Given this list of marker genes TRPC3, CYTH2, PLCL2 (NCBI Gene Id 23228), TRPC5, TRPC7, TRPC4, ITPR2, RPH3A, ITPR1, TRPC1, TRPC6, ITPR3, here is a description of the gene set: studied in species Homo sapiens Human Gene Set: GOMF_INOSITOL_1_4_5_TRISPHOSPHATE_BINDING Binding to inositol 1,4,5 trisphosphate.